The following is a description of a gene set: Genes positively differentially expressed in cell type: eTAC (extrathymic Aire-expressing cell) upon treatment with cytokine: IL-15 in mouse lymph nodes in vivo. Cytokines mediate cell-cell communication in the immune system and represent important therapeutic targets. A myriad of studies have highlighted their central role in immune function, yet we lack a global view of the cellular responses of each immune cell type to each cytokine. To address this gap, the authors created the Immune Dictionary, a compendium of single-cell transcriptomic profiles of more than 17 immune cell types in response to each of 86 cytokines (>1,400 cytokine-cell type combinations) in mouse lymph nodes in vivo. A cytokine-centric view of the dictionary revealed that most cytokines induce highly cell-type-specific responses. For example, the inflammatory cytokine interleukin-1β induces distinct gene programmes in almost every cell type. A cell-type-centric view of the dictionary identified more than 66 cytokine-driven cellular polarization states across immune cell types, including previously uncharacterized states such as an interleukin-18-induced polyfunctional natural killer cell state. Mouse Gene Set: CUI_ETAC_IL15_RESPONSE_UP studied in species Mus musculus from publication Cui A, Huang T, Li S, Ma A, Pérez JL, Sander C, Keskin DB, Wu CJ, Fraenkel E, Hacohen N (PMID 38057668), and this is the list of marker genes: Cxcl9, Psmb9, Prpf6, Samhd1, Irf7, Ctsl, Gbp7, Igtp, Cxcl10, Zbp1, Irf1, Ifi47, Bcl2l11, Ptpn1, Irgm1, Serpina3g, Bcl3, Arid5a, Stat1, Iigp1